The following is a description of a gene set: A chemical homeostatic process involved in the maintenance of a steady state level of iron within extracellular body fluids, such as blood, xylem or phloem, of a multicellular organism. This is distinct from maintenance of cellular homeostasis, which occurs within a cell. species: Mus musculus Mouse Gene Set: GOBP_MULTICELLULAR_ORGANISMAL_LEVEL_IRON_ION_HOMEOSTASIS, and this is the list of marker genes: Hamp, Hmox1, Picalm, Fbxl5, Slc11a1, Fech, Hfe, Mir17, Ireb2, Hjv, Rhd, Hyal2, Eif2ak1, Sod2, Mir122, Htt, Slc40a1 (solute carrier family 40 (iron-regulated transporter), member 1), Heph, Naglu, Neo1, Slc11a2, Tfr2, Hephl1, Epas1, Epb42, Tmprss6, Trf, Bmp6, Rhag, Ank1, Hamp2, B2m, Btbd9, Tfrc, Cybrd1